The following is a description of a gene set: species: Homo sapiens Human Gene Set: GOMF_PHOSPHATIDIC_ACID_TRANSFER_ACTIVITY Removes a phosphatidic acid from a membrane or a monolayer lipid particle, transports it through the aqueous phase while protected in a hydrophobic pocket, and brings it to an acceptor membrane or lipid particle. Phosphatidic acid refers to a glycophospholipids with, in general, a saturated fatty acid bonded to carbon-1, an unsaturated fatty acid bonded to carbon-2, and a phosphate group bonded to carbon-3., and this is the list of marker genes: PRELID3A, PRELID2, PRELID1, TRIAP1, PLTP, PITPNC1, PRELID3B